The following is a description of a gene set: studied in species Homo sapiens Human Gene Set: GOBP_PYRIMIDINE_NUCLEOSIDE_BIOSYNTHETIC_PROCESS The chemical reactions and pathways resulting in the formation of one of a family of organic molecules consisting of a pyrimidine base covalently bonded to a sugar ribose (a ribonucleoside) or deoxyribose (a deoxyribonucleoside)., and this is the list of marker genes: DHFR2, DTYMK, UCKL1, TK1, TK2